Given this list of marker genes ITGB7, TJP1, LYRM9, VOPP1, NRIP3, HEY2, GRK6, MR1, ADCY9, SLC35D2, CA13, LYST, SERPINB6, CMAHP, SERGEF, DEF6, MAPT, C1QTNF4, BBX, DCXR, CAP2, ID2, NFIC, SLC48A1, HOMER3, RSU1, RNF227 (NCBI Gene Id 284023), PCDH7, ZNF185, F2R, DIAPH1, PRKCE, TAF9B, NXF3, CASTOR1, MST1, NCOA3, PGAP6, PTGER3, GP5, UGT8, PTPRJ, ARAP2 (ArfGAP with RhoGAP domain, ankyrin repeat and PH domain 2), ARHGEF2, GSPT2, PAFAH2, ANKRD27, TLE3, IL18R1, SGK3, ZMIZ1, GDA, SHANK3, CD59, DUSP10, GRK5, FNBP1L (formin binding protein 1 like), NIBAN2, GSDMA, EEIG1, TBCEL, DNAJA4, NMNAT2, MARS2, PGM2L1, DCLK2, POPDC2, CACNA1C, STX7, GRAMD2B, IBSP, TMPRSS6, RUNX1, CDKN2C, MOB1B, TENT5A, MGAT5, TECPR2, HHEX, SAMD13, CPNE5, GNAQ, ANKRD9, DOCK11, ALOX5, RGL1, KIAA0040, EMP3, CLCA3P, MVD, CYTIP, PYGL, PITPNM1, PDLIM5, DERL1, ICAM2, SLC45A3, OPTN, BOLL (boule homolog, RNA binding protein), FERMT3, TMCC3, ST6GALNAC3, APOBEC1, FMO1, PGAP4, TSPOAP1, NDRG2, ZNF324B, ZMAT3, XKR6, YPEL5, NFE2, TRIM47, PPM1E, EPS8, TSC22D3, PLSCR4, PC, TGFA, CISH, GOLPH3, S100A13, BEX4, ORAI2, GNB4, PRXL2A, SMIM3, MPPED2, PLEK2, NBEA, KDM5B, CPNE7, HOMER1, CPT1C, MACROD2, CPLX2, RAB11A, ASB1 (ankyrin repeat and SOCS box containing 1), PRKCQ, GPCPD1, CDA, GRTP1, TMEM62, COL5A1, CDKN2B, RUSC1, TSPAN32, GPX2, TRIM26, MXD4, ENPP5, C11orf65, SERPINB9, NAGLU, UNC5CL, IFFO1, FAAH, ZDHHC9, PRKCH, SP100, ST8SIA4, TNNI3, TSC22D2, ACVR1B, IL1RL1, PCYT1B, VSIG10, ERO1B, MEAK7, DIP2C, P2RX1, ARL4D, S1PR4, PON3, SLAMF1, PPP1R13B, CDC42EP5, MOB3C, TMED8, FAM174B, KLRG1, GNA14, VCAM1, PHLDA2, SLC25A11, PCBP3, FRMD4A, SOWAHA, CA8, BCAS3, KLF6, TRIM10 (tripartite motif containing 10), NUDT11, GPR150, ARSA, TMEM64, GRN, ATXN7L1, ARL2BP, SAMTOR, TTC23, NEAT1, STIM2, CTTN, HSD3B7 (NCBI Gene Id 80270), ZFYVE16, C3orf80, NT5C3A, TG, FGD6, AKT3, FOLR1, GRB2, TTC39B, CCDC186, SLC6A20, DDIT4, RAB27B, MTCL2, PBX3, SERPINB2, RBL2, MAVS, LTC4S, TMEM9B, SCHIP1, TNFRSF18, FDFT1, MTMR12, KDM7A, LDHC, PXMP4, C16orf54, RSPRY1, PLXDC1, WDR7, CREM, BBC3, DENND2C, NOL4L, AREL1, YPEL2, GDF3, TMEM184A, OTUB2, ALDH5A1, APOE, RCBTB2, SPHK1, KLHL6, TMEM26, HMGCS2, FUOM, RFK, TOM1L1, EEIG2, ACADSB, PECAM1, ELDR (EGFR long non-coding downstream RNA), MEST, CAMK1D, PKP3, FRY, CMAS, ACAT1, LPAR6, SLC43A1, APOA1, ATP2A3, CD5L, SRXN1, here is a description of the gene set: Genes up-regulated in leukemic progenitor cells expressing activated fusion of ESWR1 and FLI1 compared to normal hematopoetic progenitors. species: Mus musculus Human Gene Set: TORCHIA_TARGETS_OF_EWSR1_FLI1_FUSION_UP from publication Torchia EC, Boyd K, Rehg JE, Qu C, Baker SJ (PMID 17875932) EWS/FLI-1 is a chimeric oncogene generated by chromosomal translocation in Ewing tumors, a family of poorly differentiated pediatric tumors arising predominantly in bone but also in soft tissue. The fusion gene combines sequences encoding a strong transactivating domain from the EWS protein with the DNA binding domain of FLI-1, an ETS transcription factor. A related fusion, TLS/ERG, has been found in myeloid leukemia. To determine EWS/FLI-1 function in vivo, we engineered mice with Cre-inducible expression of EWS/FLI-1 from the ubiquitous Rosa26 locus. When crossed with Mx1-cre mice, Cre-mediated activation of EWS/FLI-1 resulted in the rapid development of myeloid/erythroid leukemia characterized by expansion of primitive mononuclear cells causing hepatomegaly, splenomegaly, severe anemia, and death. The disease could be transplanted serially into naïve recipients. Gene expression profiles of primary and transplanted animals were highly similar, suggesting that activation of EWS/FLI-1 was the primary event leading to disease in this model. The Cre-inducible EWS/FLI-1 mouse provides a novel model system to study the contribution of this oncogene to malignant disease in vivo.